Given this list of marker genes IGF2, MGP, RGCC, PDGFRA, MASP1, WNT2, PLPP3, ADM, CPE (NCBI Gene Id 1363), CP, APCDD1, SLC5A3, F2R, TWIST2, WNT5A, SPON1, CH25H, DIO2, PAPPA, GPM6B (NCBI Gene Id 2824), WLS, CACNA2D3, SERPINE2, AKR1B1 (NCBI Gene Id 231), GGT5, FMOD, TNFRSF21, MFAP4, BMP4, CXCL6, CXCL14, CRABP2, TMEM176B, DPT, CPXM2, CXCL1, STC1, CRABP1 (cellular retinoic acid binding protein 1), APOD, PTGDS, MGST1, TNFRSF11B, DLL1, IGFBP2, MRPS6, CCL2, PLPP1, CCL11, SPRY1, PRSS12, here is a description of the gene set: Genes upregulated in subsets of cells of a given type within various tumors Human Gene Set: GAVISH_3CA_METAPROGRAM_FIBROBLASTS_CAF_7 from publication Gavish A, Tyler M, Greenwald AC, Hoefflin R, Simkin D, Tschernichovsky R, Galili Darnell N, Somech E, Barbolin C, Antman T, Kovarsky D, Barrett T, Gonzalez Castro LN, Halder D, Chanoch-Myers R, Laffy J, Mints M, Wider A, Tal R, Spitzer A, Hara T, Raitses-Gurevich M, Stossel C, Golan T, Tirosh A, Suvà ML, Puram SV, Tirosh I (PMID 37258682) In this study, an extensive analysis was conducted to define meta-programs (MPs) capturing intra-tumor heterogeneity across a spectrum of tumor types. The approach utilized non-negative matrix factorization (NMF) to analyze each cell type separately within individual tumor samples. This involved the analysis of malignant cells, macrophages, fibroblasts, endothelial cells, epithelial cells, T-cells, and B-cells. NMF was executed with varying parameter values (K=4, 5, 6, 7, 8, 9), thereby generating 39 programs for each cell type per sample. Each NMF program was summarized by the top genes based on NMF coefficients.\nRobust MPs were then delineated for each cell type using a set of stringent criteria, including recurrence within the same tumor, similarity to programs in other tumors, and non-redundancy within a tumor. Subsequently, these robust NMF programs were clustered (per cell type) based on Jaccard similarity, leading to the identification of MPs associated with each cell type.\nTo enhance the quality of the MPs, a refinement steps were undertaken, involving the removal of MPs suspected of reflecting low-quality data (with an overrepresentation of ribosomal proteins or mitochondrial-encoded genes), single-study inclusion, or similarity to miss-annotated cell types. studied in species Homo sapiens